Given this list of marker genes GPX3, S1PR1, SLC25A18, SPARCL1, PGM2, SCRG1, DDX24, LRATD2, TBC1D10A, RIT2, ADD3, ETV1, AGT, TMEM126B, DHCR7, MASP1, ADORA2B, MMAB, EIF6, APOE, MRPL19, ZNF302 (NCBI Gene Id 82167), SELENBP1, CD82, NHERF1, ANOS1, HMGN3, EFNA1, VEPH1, SPTLC1, here is a description of the gene set: from publication Zhong S, Zhang S, Fan X, Wu Q, Yan L, Dong J, Zhang H, Li L, Sun L, Pan N, Xu X, Tang F, Zhang J, Qiao J, Wang X (PMID 29539641) Human Gene Set: ZHONG_PFC_C1_ASTROCYTE studied in species Homo sapiens